The following is a description of a gene set: Reactome Pathway: NR1H2 & NR1H3 regulate gene expression to control bile acid homeostasis part of: NR1H2 and NR1H3-mediated signaling Liver X receptors NR1H3 (LXR alpha) and NR1H2 (LXR beta) are sterol-responsive transcription factors that become activated upon the engagement with their cognate oxysterol ligands. Besides inducing a genetic program aimed to reduce the cellular sterol load, ligand-activated NR1H2 & NR1H3 also modulate the expression and activity of genes controlling bile acid synthesis, transport and metabolism such as bile acid-glucuronidating enzyme UGT1A3 which converts hydrophobic bile acids into polar metabolites that can be excreted in the urine (Verreault M et al. 2006). species: Homo sapiens, and this is the list of marker genes: RXRA, RXRB, FABP6, NR1H3, NCOR2, UGT1A3, NCOA1, NR1H2, NCOR1